Given this list of marker genes PSMA3, S1PR4, S100A6, TOR4A, BMPR1A, DIPK1A, F2RL1, APLP1, RNF43, FBXL4, CYFIP1, HIPK1, CDR2, MTHFD2, VPS28, EEA1, TNFRSF13C, CSRP2, PSME2, FBN2 (NCBI Gene Id 877), ARHGAP31, CRYL1 (crystallin lambda 1), PLD1, KLRG1, VSIG10, IQGAP2, LCA5, RAB1A (NCBI Gene Id 5861), ARSB, KBTBD7, LIPT1, PNP, CR2, HSPA2 (heat shock protein family A (Hsp70) member 2), ERBB3, MAP3K4, SLC46A3, SHE, RPSA, PPCS, EMP3, ICAM1, CCR10, LATS2, FAM81A, FAM89A, HEPACAM2, RNF19B, ELOVL1, ADAM19, ENTPD1, AFG2A, IKZF3, MYO1F, ELL2, RNF146, TIMP2, NKAP, THTPA, JADE1, PIM1, CCR4, NLN, DHRS7, CDIPT, TMED5, AP1S2, BTBD19, RIPK1, SCOC, MYNN, PLCL1, MID1IP1, SLC25A32, CEBPB, TKTL1, DIPK2A, CDH13 (cadherin 13), ITGAV, RIN2, CEMIP2, TBC1D14, ETAA1, AXL, PXYLP1, KLF3, DENND5A, CCNG1 (cyclin G1), DONSON, TAF9B (TATA-box binding protein associated factor 9b), IL18, ELMO1, GNA15, CCDC126, COQ8A, SEC23A, SARAF, AP5M1, SLC22A5, C6orf89, COBLL1, RBPMS2, OSTM1, MANSC1, C2orf68 (NCBI Gene Id 388969), GALM, RRM2B, SIDT1, SNAI2, C9orf85, GALNT4, LGALS1, GZMB, ADRB2, RNH1, RAP1A, TRIM59, SNX30, DIAPH2, IGLC7, CLIP1, VIRMA, TESC, NCMAP, CPM, ECI1, TASP1, RNASET2, SGSH, TAF5L, SNX20, UBXN2B, RFLNB, SLA, AREL1, IL10RB, ANGPTL2, LPAR6, RNF128 (NCBI Gene Id 79589), CERS4 (NCBI Gene Id 79603), BSCL2, REPIN1, CC2D2A, SORBS1, CD84 (NCBI Gene Id 8832), RIPK2, FGD2, SLC25A33, SLAMF6, PTPRJ, EGLN3, GPR160, LY96, ELL3, IL6R (interleukin 6 receptor), OXR1, HERPUD1, GCNT1 (NCBI Gene Id 2650), CDC25B, ALOX15B, CRLF3, LYPLA2, PRDM1, FOXN2, MAF, ST6GALNAC6, CASS4, AVEN, PSEN2, MED8 (mediator complex subunit 8), MFSD1, NCK2, ACOT11, CCR5, RAB31, DCXR, BPNT1, CKLF, ARHGEF12, GBP4, KCNK6, ALAD, SRPK3, CRK, TSPAN14, NFIL3, TM7SF3, SERTAD3, RPIA, PHYKPL, SEC11C, INPP1, SAG, PNPO, SYT11, SPRTN, TRAF5, FPGT, IFNG, GRHL1, here is a description of the gene set: The transcription factor FoxP3 partakes dominantly in the specification and function of FoxP3+ CD4+ T regulatory cells (Tregs), but is neither strictly necessary nor sufficient to determine the characteristic Treg transcriptional signature. Computational network inference and experimental testing assessed the contribution of several other transcription factors (TFs). Enforced expression of Helios or Xbp1 elicited specific signatures, but Eos, Irf4, Satb1, Lef1 and Gata1 elicited exactly the same outcome, synergizing with FoxP3 to activate most of the Treg signature, including key TFs, and enhancing FoxP3 occupancy at its genomic targets. Conversely, the Treg signature was robust to inactivation of any single cofactor. A redundant genetic switch thus locks-in the Treg phenotype, a model which accounts for several aspects of Treg physiology, differentiation and stability. Genes up-regulated in CD4 T conv over-expressing: GATA1 and SATB1 versus control. species: Homo sapiens Human Gene Set: GSE40277_GATA1_AND_SATB1_TRANSDUCED_VS_CTRL_CD4_TCELL_UP from publication Fu W, Ergun A, Lu T, Hill JA, Haxhinasto S, Fassett MS, Gazit R, Adoro S, Glimcher L, Chan S, Kastner P, Rossi D, Collins JJ, Mathis D, Benoist C (PMID 22961053)